Given this list of marker genes ARG2, LRRC32, LGALS9B, IL20RB, IL4I1, FOXP3, VSIR, CLEC4G, TNFRSF21, PRKAR1A, CD86, RIPOR2, TNFRSF14, CASP3, LGALS9C, GNRH1, XCL1, BTN2A2, BTLA, CDKN2A, PLA2G2F, HLA-G, SLC4A2 (NCBI Gene Id 96677), FOXJ1, PDCD1LG2, CEBPB, SPN, CD274, TMEM131L, IL10, HLA-E, ERBB2, LILRB4, ITCH, LGALS9, MAD1L1, GPNMB, LILRB1, PAWR, MIR181C, IL2RA, TSPAN32, DLG5, SCGB1A1, PELI1, CRTAM, IHH, SFTPD, CD80, VSIG4, CR1, TWSG1, VTCN1, ZBTB7B, MARCHF7, RC3H1, IDO1, PLA2G5, PRNP, CBLB, DLG1, SDC4, TGFB1, BMP4, NDFIP1, LAPTM5, SCRIB, LILRB2, SHH, PLA2G2D, GLMN, PTPN6, ARG1, PTPN11, CTLA4, PLA2G2A, HLA-DRB1, HAVCR2, CD37, here is a description of the gene set: Any process that stops, prevents or reduces the rate or extent of T cell proliferation. species: Homo sapiens Human Gene Set: GOBP_NEGATIVE_REGULATION_OF_T_CELL_PROLIFERATION